Given this list of marker genes Panx1, Slc25a24, Slc25a17, Lrrc8a, Slc25a31, Slc25a23, Slc25a25, Slc35b1 (solute carrier family 35, member B1), Slc35b3, Slc17a9, Slc25a42, Slc25a41, Slc25a54, Slc25a4, Slc19a1, Slc46a2, Ank, Slc35b2, Slc25a5 (solute carrier family 25 (mitochondrial carrier, adenine nucleotide translocator), member 5), here is a description of the gene set: studied in species Mus musculus Enables the transfer of a purine ribonucleotide, any compound consisting of a purine ribonucleoside (a purine organic base attached to a ribose sugar) esterified with (ortho)phosphate, from one side of a membrane to the other. Mouse Gene Set: GOMF_PURINE_RIBONUCLEOTIDE_TRANSMEMBRANE_TRANSPORTER_ACTIVITY